Given this list of marker genes CHMP2A, ANKRD20A4P, PARP8, PPP1R10, B3GALT4, G2E3, MICU2, UBAC2, SLC66A3, SKP1, TMEM175, ZNFX1, FAM107B, TMEM267, RNU5E-6P, MIR3190, SNORA24, AKAP8, TM7SF3, SLC7A5P2, PSCA, MKNK2, BIN1, ID2, USP4 (NCBI Gene Id 7375), KCNH1, PHLDA2, GSK3B, SPECC1, LRRC74B, NDUFAF3, MARCHF7, RNU2-63P (NCBI Gene Id 106480225), SH3BP2, MDC1, PCBP2, PDE6D, ASMTL, CSKMT, CDKL3, UBE2D3, ZFAND2A, S100A2, TRAF3IP2-AS1, UBE2B, SLC3A2, BCL7A, SHANK1, STAT1, PRDM10-DT, VARS1, TEFM, H6PD, VRK2, TOB1, MRPL34, PCID2, RNU4-1, RPS16, SUPT4H1, MARCHF6, FRG1-DT, MMP17, MCCC1, CDK6, AKR1C3, EXD3, MCM8-AS1, NBPF26, RNVU1-27, TNRC6C, ARL6IP1, ZNF527, SIRT7 (NCBI Gene Id 51547), LTA4H, GGNBP2, SIRT1, KLF7, VPS36, DHX33-DT, PROK2, CEP170B, PARP1, CFD, NME1, FSCN1, EPS15, NR3C1, IGLV6-57, UBA2, RPL3, TATDN3, CENPU, C17orf49, GARS1-DT, MAP3K8, TMEM41A, TAF2, VPS37D, H1-5, WDFY1, IKZF1, DALRD3, CFLAR, DFFB, POLR2J4, RNVU1-28, NDUFC2-KCTD14, NCDN, MTRES1, NCALD, TAF1C, RPL5, BORCS5, GAPDH, MIR7845, LRP3, KCNJ2, ARHGDIA, RAPGEF6, MT-RNR1, P2RX6P, YPEL3, CHD2, WWP1, DHX9, EIF3D, PPP1R3B, LINC02218, RILP, PARN, ARHGAP4, SERPINI1, ZNF706, SCRT1, FOXN2, JUNB, ZNF529, ARL14EP, KLHL20, MIR4727, FAM76B, GAK, APRT, GAS5, HOOK3, TRIM8, LINC01126 (NCBI Gene Id 285048), MBD3L1, SLC37A2, VASP (NCBI Gene Id 7408), CEP128, EXOC3-AS1, MBP, MIR5087, RNU12, LILRP2, ARFIP2, FLOT1, GTF2A1, SNHG8, USP3, RNA5SP19 (NCBI Gene Id 100873274), NSFL1C, FAM118A, TRPC4AP, RNVU1-26, RIPK2, CUEDC1, CFAP418, RPL13A, SPRED2, PMEL, CHRAC1, CHEK1, DHFR, GPN2, NPC1, DLEU2, DMAP1, ZNF517, NDST2, SAP18, NME1-NME2, RNVU1-6, CA3-AS1, GEMIN8 (NCBI Gene Id 54960), EGR1, AARS2, VSIR, DOCK2, CTNNB1, SNHG1, ENSG00000231424, BFAR, RETNLB, GNB2, TXNIP, RPL24, FLNA, ZFP62, TNFRSF11A, SLC39A3, PDE2A-AS1, BCORL1, KCNH1-IT1, TRABD2A (NCBI Gene Id 129293), ABHD5, TIALD, BACH1, RPL18P10, CUL4A, AFF1, LINC02846, NOXA1, H3C7, PRKCB, SNORD12C, SEMA4D, ABHD15-AS1, ARHGAP22, CCDC157, CUL7, MYBBP1A, MTDH, PDE2A, KCNN3, SPPL2A, RN7SK, SMIM8, SRSF2, COTL1, FPGS, RNF187, RHBDD3, ZFAND2A-DT, TMEM230, ZNF276, LRSAM1, ANKRD19P, PPCDC, SAMD4B, WDR11-DT, POLD1, JMJD8, KMT2A, DNAJB1, DIS3L2, CCDC59, ZNF426, TMEM221, OGT, STK35, ENSG00000246308, DUS1L, ZNF506 (NCBI Gene Id 91115), RNF220, GTF2A1-AS1, JPT1, APOL2, MIR7-3HG, UTP4, SNORA13, CALM1, CEBPA-DT, ATF4, CBX3P2, POM121, MAP4K4, MFSD11, CCT4, DEF6, SACM1L, PDE4C, RPL36A-HNRNPH2, BSG-AS1, WDR74, TPI1, PIGG, DDX1 (DEAD-box helicase 1), RNVU1-31, MRPS31P5, YWHAZ, SYCE2, BAIAP2, KIF22, H2AC21, DGAT1, ZNF721, RNU4-71P, RSRC2, VPS51, POLR2C, NCBP3, SARDH, NNT-AS1, RNU4-2, MAML2, TNFRSF10A-DT, RGS3, KAT6A, RNVU1-15, PHYHIP, UBE2L5, FTL, RWDD3 (NCBI Gene Id 25950), KNL1, LRRC37A15P, IL10RB, EEF1AKMT2, MIR5696, H2AX, PDCD10, GTF2A2, ZNF84-DT, SNRPB2, H2BC18, NFKBIA, JSRP1, ARMCX5, TIPARP-AS1, RNF186, RC3H1-DT, SLC27A1, KXD1, NOTUM, EEF1A1, NSUN4, MT-TF, ADNP, RNU7-90P, ST6GALNAC6, ANKRD31, ZNF805, MED23, ARRDC3, LINC02980 (long intergenic non-protein coding RNA 2980), FOXJ3, RPS12, RPS27, TSPOAP1-AS1, KCNJ2-AS1 (NCBI Gene Id 400617), SMURF2, EIF4A2, PIGO, MYC, SNAP25-AS1 (SNAP25 antisense RNA 1), TUBA1B-AS1, CYP2W1 (NCBI Gene Id 54905), METTL26 (methyltransferase like 26), INTS6-AS1, NOP53, SUPT20H, KCTD6, RING1, RNU5B-1, CEP104, MAP2, H2BC8, EIF4G2, ZBP1, RN7SKP249, CEP131, RNVU1-21, SNORD54, BNIP3P11, BAIAP3, TET2, TTC7A, FBXL4, PABPC1, POLDIP3 (DNA polymerase delta interacting protein 3), RUNX1, MIR3143, FASN, SLC8A2, RERE, ZNF143, ODC1-DT, UPF3A, BMF, SPTAN1, ENSG00000283078, FAM201A, RNF183, RNU11, IQCH-AS1, H2AC11, SBF2, ZSCAN31, CAPS2, EWSR1, ANO10, TLR9, FUT10, ALDH1L2, TMX4-AS1, NXF1, ANKMY1, KLF6, BEND3, ZBTB4, TRIM7-AS2, AGBL5-AS1, STT3B, ZNF337, ENSG00000228395, JPX, TARS3, ALOX12, IER3, SNORD101, ZNF839, RBBP5, PRR27, HMGB2, KRBA2, H4C16, TCTN3, NALT1, MIR7-3, RRP7BP, ING1, RNU6-1257P, NCAM2, ZNF101, GPAA1, H4C1 (NCBI Gene Id 8359), ANPEP, HNRNPM, TAFA2, ENSG00000199470, DRAP1, UBE2D3-AS1, TMEM184A, CYC1, MPDU1-AS1, LINC01058, MIR7155, REPIN1, SQSTM1, SNHG19, SLC22A18, LIMD1-AS1, UVSSA, MYNN, SPHK2, SEC14L1, SAT1, MGRN1, CHTF8, LITAF, CFL1, DDX5, DNAJB14, IPO4, SRSF7, LINC02029, MYEOV (myeloma overexpressed), RPS20 (NCBI Gene Id 6224), SNORA16A, FAM227B (family with sequence similarity 227 member B), MYBPH, FRA10AC1, F2RL3, AGK-DT, RAC2, STING1, GRK6, H2AZ1, LIG1, ACTG1, MIR5695, SH3TC1, TRPV3, ABTB2, KDM4B (NCBI Gene Id 23030), OARD1, ZC3H12A, ERCC1, SNORA78, C1orf53, H2BC15, BTK, TRIM8-DT, NMUR1, H2BC11, C11orf98, DUSP2, MRPL40, SORBS3 (sorbin and SH3 domain containing 3), NAT14, TMSB4X, RNASEH2B, TRIM25, HSP90AB1, ARMT1, CCDC88B, IGHMBP2, ZNF451-AS1, PDCD6, SAT1-DT, PABPC4, CCDC106, IBA57-DT, CENPH, SNAI1, ENSG00000232995, UBE3D, CEBPA, EIF1, FAM178B, EDC4, SH3GL1, LSM14A, H2AC13, GSDMD, MIR1302-3, KNTC1, PIGO-AS1, SERPINB1, FLOT2, TBC1D10A, GOLGA7, H2BC21, MTUS2, NYAP1 (NCBI Gene Id 222950), C8orf82, RNU6-9, TTLL12, ZNF107, EOGT-DT, FUS, WHAMMP2, LTBP3, FRMPD1, TRAPPC5, ANKRD33B, ZNF236-DT, CNOT6, HBS1L, TUBB, ATP5F1A, RN7SL824P, C18orf21P1, EOGT, NSMAF (neutral sphingomyelinase activation associated factor), RDH5, SPIDR, BAG2, ZNF888-AS1, TOB2, PHF11, C15orf48, RWDD3-DT, H3-3B, RNF170, MIR3188, ID2-AS1, ERLIN2, NCLN, PARVG, SPECC1-DT, FADD (NCBI Gene Id 8772), DIDO1, MIR194-2HG, MIDN, GTF3C6, PITPNC1, GUSBP2, ODC1, AP4E1, ARID1A, GATAD2A, PLCH2, RNU5A-1, KLF13, PI16, SNHG7, TNFRSF10D, NABP1, RNVU1-19, JUND, SLC36A4, TFRC, BSG, ABHD12, ETV5, POLR2A, ALG1L13P, RMND1 (NCBI Gene Id 55005), ARID3A, SCAMP3, NLRX1, NCOA3, CD68, CDK12, TNFAIP3, ACTL8, RGS5, CIZ1, H1-2 (H1.2 linker histone, cluster member), C6orf62, CCNT1, BIN3, TMEM242, TM7SF2, PLCG2 (phospholipase C gamma 2), TNFSF9, RNU5F-1, MRPS18B, ENSG00000273162, MAML3, MPDU1, ICAM1, JRK, VPS28, ENSG00000183154, H1-10, NUDT3, SYNCRIP, LRRC1, TAF4, C6orf226, C11orf68, GARS1, AP3B1, SRRM3, SLC9A1, ZCWPW1, LRRC14, NPM1, FHL3, H2BC12, RNF149, RNU5E-4P, TOB1-AS1, MYO5B, LINC01719, DDX18, TGFBR2, CD244, PLXDC1, TRPM2 (NCBI Gene Id 7226), NDUFC1, LRRC37A3, ITGB2, HSH2D, RAB11FIP1, CSRNP2, DTWD1, H2AZ1-DT, DHX33, SLC20A1-DT, ENPP3, CYP1B1 (NCBI Gene Id 1545), WDR1, SLC48A1, TRDMT1, ENSG00000267024, DNAJB4, SERINC5, HERPUD1, TMX4, TCEA1, DOHH, ZNF131, ATXN2L, TSPOAP1, KIF3B, MRPL21, TMEM223, RPLP1, CALM2, INTS6, RPL30, UXS1, SMG1P3, RC3H1, ZNF786, VPS13D, SNORD26, MTF2, RPS15A, RNVU1-14, ANXA9, KCNN2, LINC03108, TOR1AIP1, POLR3E, CDC25C, ZNF846, RAB14, LOH12CR2 (NCBI Gene Id 503693), C5orf24, RPL12, RRS1-DT, MCRIP2, METTL25, COX20, GTF2IRD1 (GTF2I repeat domain containing 1), GSK3B-DT, RHEX, CHD9, CCDC88A, CIRBP, SNHG12, SNORD60, NDUFS7, ARSG, H4C3, POLR3H, RCOR3, COPB1, EPC1-AS1, INTS12, DENND4B, C15orf61, SEC24C, C2CD5, SLC38A2, TMEM50B, SUN2, ANKRD18A, RPS17, EPB41L4A-AS1 (NCBI Gene Id 114915), TIMM10B, KIAA0319L, NDUFA4, MED4, AFF3, ZNF513 (zinc finger protein 513), FAM53C, MALAT1, AMACR (NCBI Gene Id 23600), NADK, VPS9D1, INAFM1, PPARD (peroxisome proliferator activated receptor delta), ITPR1-DT, LATS1 (large tumor suppressor kinase 1), CCDC78, TRMO, LNPEP, PLEKHG2, SF3A1, DDX60L, STX18-AS1, CA2, GEMIN6, DUSP6, NUFIP2, NOTCH1, TAGLN2, RNU6-1, PKNOX2, ARHGEF1, ADAT2, ANGEL1, NDUFA11, IL10RB-DT, HNRNPAB, RRS1, MSH3, SCRIB (scribble planar cell polarity protein), IL17C, REV3L, ZNF77, DRG1, ZNF888, TMEM123, EPC1, ZMIZ2, CERNA3, GTF3C3, NCF4, ADAP2, USE1, ISG20, POLG-DT, SNORD3A, PSMD9, NOP56, RPL36, NFE2L2, ZSWIM9, IMPDH2, STAU2, TJP3, USP15, TUBA1B, TP73, USP42, GADD45B, PPP2R5C, SLC7A6, SIGLEC6, RAD23A, SNORD25, ST20, KDM3B, RPS26, ACTB, GASAL1, CCDC183 (coiled-coil domain containing 183), MBD6, ITPR1, NSL1, LRP12, PEX3, DUSP22, POLL, UBB, GABARAP, CDK6-AS1, LINC01556, GSTA4, ANKRD18B, SNORD27, MRPS15, BMS1, SNHG5, DDX11L10, KMT5B, PPP2R2A, ACSF3, MED16, LINC00240, PXK, CWC25, ANTKMT (adenine nucleotide translocase lysine methyltransferase), NUMBL, RAPGEF1, SMARCD2, ZFAS1, ELAC1, CRLS1, STX18, RNF44, ZNF558, ZNF143-AS1, CARS2 (NCBI Gene Id 79587), HTR5A, SNORA57, QKI, GAS7, IBA57, CFAP251, TXLNA, KRBOX5, ZNF84, PPEF1, LINC02642, LITATS1, MFAP4, RNF139-DT, IER5, BCAR3, CDKN1A, TIPARP (TCDD inducible poly(ADP-ribose) polymerase), SNHG9, SMCHD1, BCAS4, HEATR5A-DT, RPL18, MIS18BP1, SNHG6, EMC1, PLAUR, TDRD7, SLC1A5, AGBL5, REEP3, PRDX1, DDIT4, PPP1R15A, DPY19L4, SNX18 (sorting nexin 18), SLC7A5, ENSG00000201465, TNFRSF10A, GBA1, VANGL1, IRS2, CEP57, TBL3, BAIAP2-DT, PHLDA1, RNU5E-1, ASF1A, SNORD43, TMCO3, EEF1AKMT1 (EEF1A lysine methyltransferase 1), RAB18, ZCCHC4, NDRG1, DPP9, NDUFC2, CHRNA3, JADE1, MIR5708, DCUN1D2, CBFA2T3, NUF2, RNU5D-1, SLC20A1, WDR11, TCF4, KRT8P46, AMD1, VPS26C, DPP8, FRG1 (FSHD region gene 1), TFEB, TIGD6, TRAF7, TMCO4, AKIRIN2, PPA2, AGK, PPM1F-AS1 (PPM1F antisense RNA 1), TUBB4B, NME4, COMMD1, PIP4P2, MAT2A (NCBI Gene Id 4144), ACER3, TGOLN2, YAP1, LAMA5, PTEN, PIEZO1, PTAR1, IRF8, GSTCD, SUPT5H, CCDC136, RNVU1-18, LINC02863, LINC01623, C15orf39, LRRC59, TNFSF13B, EEF2, PCTP, ZBTB37, PPP6R1, SSBP2 (NCBI Gene Id 51492), BOLA1, HIRA, OCSTAMP (NCBI Gene Id 440764), DGKD, H2BC13, TMEM242-DT, CEP95, MIR4674, UTP6, DPCD, POLG, AMDHD2, DRG2, RPS4XP16, SH3BP1, MEPCE, AK3P2, DUSP1, COPS7B, KDM4A, CCDC97, GNPDA2, INPP5E, SNHG17 (small nucleolar RNA host gene 17), PHC3, CXCR4, KAZALD1, UBE2S, ZNF775, MCTP1, PHLDA1-DT, KATNBL1, RNU6ATAC, HSPA6, SLC16A3, IER3-AS1, CPNE8, RN7SL449P, PDCD6-DT, PARAIL, DDIT3, RPS7, RPS2, DEGS1, CPSF1, PRKCZ (NCBI Gene Id 5590), RPL36A, BRWD1 (bromodomain and WD repeat domain containing 1), HCG14, RNU2-2P, C6orf47, OAZ1, HEATR5A, TUBA1C, here is a description of the gene set: species: Homo sapiens Genes containing one or more binding sites for (CHAF1B) in their promoter regions (TSS -1000,+100 bp) as identified by GTRD version 20.06 ChIP-seq harmonization. Human Gene Set: CHAF1B_TARGET_GENES from publication Yevshin I, Sharipov R, Kolmykov S, Kondrakhin Y, Kolpakov F (PMID 30445619)